Given this list of marker genes TBCK, EIF4H, PIH1D1, GLRX3, GPR183, MED20, ITGAX, TMEM68, CAPRIN1, TAGLN2, CYP24A1, ANO6, REG1B, UQCRH, CCT4, SLC25A20, RABL3, KBTBD4, RSL1D1, MSRA, TMEM239, SERPING1, ADAM11, TBRG4, VBP1, TRPV2, ATP8B1-AS1, LGALS1, VPS26B (NCBI Gene Id 112936), KDM4C, IPO4, PGM2, C1QBP, SNAPC3, BIN2, MRPL37, NOC2L, RASA3, UNC13D (unc-13 homolog D), MOB4, MRPL19, SHISA5, NTS (NCBI Gene Id 96646), PRIM1, SLC24A5, ENTPD6, GLCE, PPP4C, MYH2, PLGRKT (NCBI Gene Id 94530), RETNLB, TENT5D, TAAR5, IK, DENND2A, ROPN1L, ABCF3, SNRPE, C11orf24, MRPL42, PSMB8, C3orf62, ZNF578, PPID, HEY1, TMEM59, TMEM209, PDCL2, HSPA8, OXSR1, AMIGO2, GPATCH3, MPLKIP, TMEM106B, NNT, TRIM62, LRRC45, EIF3I (NCBI Gene Id 8668), RNF8, CORO6, NAE1 (NEDD8 activating enzyme E1 subunit 1), ANXA2, IL1R1, DVL1, APEH, LINC01530, ARAF, ZNF267, LSM6 (LSM6 homolog, U6 small nuclear RNA and mRNA degradation associated), RHOA, DDT, LINC00347, TXLNGY, SGPP2, PRCP, SRSF5, ITGB7, TEX28, SRL, MOG, UBE2D3, TMEM19, DOK2, SCD5, HMGXB3, MRPL20-AS1, GGA2, TMEM141, NDUFS7, TCP1, SDHB, ZNF692, RAN, LRFN3, CHTF8, PDCD6IP, ARHGDIB, PFKL, COPS6, CENPK, CCNDBP1, TRMT1, PNRC2, GON7, POTEKP, TMEM123, NRG4 (neuregulin 4), ANKRD27, BLOC1S4, SERPINB1, ICAM4, KCTD18, ANKRD16, MYC, COX10, PPP1CA, RHOB, MVP, TTC6, TMX1, SAMD12, ANXA4, HCFC1R1, BLTP2, TM7SF2, EIF4A1, ZMYM6, QSOX1, NOP9, ADK, KLRC3, SNTG1, KRT40, LINC00842, IRF9, ZNF736, METTL4, IL7R, MED6, RGS9BP, MCRS1, NR1H3, ZNF92, UMPS, EMP3, SYNM, METTL27 (methyltransferase like 27), NMT2, SNRPD1, SLC19A1, S100A4, PROCR (protein C receptor), GABRB3, OR2C3, GGCT, TGIF1, CARHSP1, CDKN2D, RFC2, LTBP3, MPDU1, NAALADL1, BCL2L10, NCBP1, FRMPD3, TARP, GLUD2, ZNF277, RFXANK, EML2, ERICH3, RBM7, KATNIP, DLD, HPSE, CATSPERD, here is a description of the gene set: Human Gene Set: GSE27291_6H_VS_7D_STIM_GAMMADELTA_TCELL_UP We used microarrays to detail the global programme of gene expression by circulating TCRVgamma9+ gamma delta T cells isolated from healthy individuals,tested either as resting cells or cells activated by phosphoantigen BrHPP and IL-2at an early(+6hrs) and a late (+7days) timepoint. We find that with more “NK cell” genes than alphabeta T cells and more “T cell” genes than NK cells, the circulating TCRVgamma9+ gamma delta T cells cells have a hybrid transcriptome. The gene signature of the activated cells recapitulates their physiological functions: Th1 cytokine, chemokine and cytotoxic activities at first and mitotic activity at later time points. The gene expression pattern of activated normal gamma delta T cells is nevertheless clearly distinctive from that of NK/T and peripheral T cell lymphomas of the gamma delta subtype. studied in species Homo sapiens from publication Pont F, Familiades J, Déjean S, Fruchon S, Cendron D, Poupot M, Poupot R, L'faqihi-Olive F, Prade N, Ycart B, Fournié JJ (PMID 21968650) Genes up-regulated in gamma delta T cells activated by phosphoantigen BrHPP and IL2: 6h versus 7 days.